Given this list of marker genes Gapdhrt, Gapdhrt2, Grin2b, Dlgap2, Ctnnb1, Grid2ip, Dlgap1, Cdkl5, Fyn, Grin2a (NCBI Gene Id 14811), Cript, Lyn, Snx1, Cit, Yes1, Exoc4, Sh3gl1, Prr7, Grip2, Sipa1l3, Ina, Wwc1, Nos1, Tanc1, Lin7b, Gapdh, Iqsec2, Dlg1, Syngap1, Fabp5, Lck, Nr3c1, Nr3c2, Bcr, Akap1, Dlg3, Psd, Baiap2, Cabp1, Ctnnd1, Actn2, Shank3, Src, Iqsec1, Slc30a1, Dicer1, Cfl1, Abr (active BCR-related gene), Arhgef2, Tanc2, Ctnna2, Ptk2b, Dnm2, Sh3gl3, Akap5, Zdhhc5, Tnik, Fam81a, Gphn, Gria1, Anks1b, here is a description of the gene set: A network of proteins adjacent to the postsynaptic membrane. Its major components include the proteins that spatially and functionally organize neurotransmitter receptors in the adjacent membrane, such as anchoring and scaffolding molecules, signaling enzymes and cytoskeletal components. species: Mus musculus Mouse Gene Set: GOCC_POSTSYNAPTIC_SPECIALIZATION_INTRACELLULAR_COMPONENT